Given this list of marker genes LMO4, PI4KB, RHOH, TIRAP, HLA-DQB1, RRAS (RAS related), CACNB3, SOCS1, LILRB1, HDAC5, FZD7, GAP43, TAX1BP3, FCRLA, PIM2, SARS1 (NCBI Gene Id 6301), GZMH, MYEF2, PTPRA, KIN, ATP6V1A (ATPase H+ transporting V1 subunit A), MYL4, KIF23, CRYAA, DDX51, ENPP1, SEC62, SAMD10, TRIM46, here is a description of the gene set: Gene expression profiles of five consecutive stages of mouse B cell development were generated with high-density oligonucleotide arrays from as few as 2 x 10(4) ex vivo isolated and flow-cytometrically purified cells. Between 2.8% and 6.8% of all genes change on differentiation from one cellular stage to the next by at least twofold. The entire pathway involves differential expression of 10.7% of all genes. Previously known expression patterns of genes (like surrogate light chain, RAG-1/2, MHC class II, mel-14 antigen) are confirmed. The gene expression patterns of the proliferating pre-BI and large pre-BII cells on the one hand, and the resting immature and mature B cells on the other hand, are most similar to each other. Small pre-BII cells display a pattern that is transitional between these two groups. Most of the genes expressed in early precursors are involved in general processes, like protein folding or cell cycle regulation, whereas more mature precursors express genes involved in more specific molecular programs (cell surface receptors, secreted factors, and adhesion molecules, among others). Between 19 and genes share a given expression pattern. Combining knowledge about gene function and expression pattern allows identification of novel candidate genes potentially involved in self-maintenance of pre-BI cells, allelic exclusion and pre-B cell receptor signaling in large pre BII cells, cell-cycle arrest of small pre-BII cells, propensity toward apoptosis or anergization in immature B cells, propensity toward cell division and activation in mature B cells, and stage-specific interactions with stromal cells in the bone marrow. Genes up-regulated during differentiation from pre-BI to large pre-BII lymphocyte. species: Mus musculus from publication Hoffmann R, Seidl T, Neeb M, Rolink A, Melchers F (PMID 11779835) Human Gene Set: HOFFMANN_PRE_BI_TO_LARGE_PRE_BII_LYMPHOCYTE_UP